Given this list of marker genes Ctsh, Crym, Aldh1a3, Thra, Pkm, Thrb, here is a description of the gene set: Mouse Gene Set: GOMF_THYROID_HORMONE_BINDING studied in species Mus musculus Binding to thyroxine (T4) or triiodothyronine (T3), tyrosine-based hormones produced by the thyroid gland.